The following is a description of a gene set: Human Gene Set: GSE20198_UNTREATED_VS_IL12_IL18_TREATED_ACT_CD4_TCELL_UP The aim of this study was to identify genes regulated by IL-12, IL-18 and IFN-alpha during early differentiation of human Th1 cells from publication Filén S, Ylikoski E, Tripathi S, West A, Björkman M, Nyström J, Ahlfors H, Coffey E, Rao KV, Rasool O, Lahesmaa R (PMID 20304822) Genes up-regulated in the activated CD4 T cells (48h): control versus IL-12 and IL18. species: Homo sapiens, and this is the list of marker genes: NDUFS6, SLC66A1, SYCP2, USP6NL, HAP1, AKR1C2, MYO5A, ASB13, PITX2, MT2A, ACOT8, LENG1, GRIN2D, ENTPD6, UNC13B, AGPAT3, WDR11, CYP4V2, NRARP, EPS8L1, PINK1, IDH3G, RAD51D, FOXO4 (NCBI Gene Id 4303), DVL3 (dishevelled segment polarity protein 3), CADM3, KCND1, FITM1, GPR180, MMRN2, PKDREJ, SLC25A28, KCNC2, KANSL3, ARHGAP28, WEE1, SNX7, MORN4 (NCBI Gene Id 118812), CSF2RA, PGS1, IRS2, DYNC2I2, FBXL18, TEX47, AK3, KCNAB2, C16orf90, MAP1S, AK4, SF3B2, RNF157, MAP3K2, LMAN2L, TREML2, STAG2, GET4, COL27A1, NKD2, NR1H2, LRP6, IKZF1, BCL2A1 (NCBI Gene Id 597), MYPOP, GRN, NONO, SLC25A40, RTN4RL1, ENTPD7 (NCBI Gene Id 57089), ZFP57, UBASH3A, HELB, EIF5A2, L1CAM, TCAF2, PTPRZ1, WDR7, PCBP2, RNF123, WDR82, KLHL22, RAB11FIP1, ADI1, BIRC7, HDAC1, ERGIC3, CASQ1, RNF19A, STX3, SEC22C, RBBP4, VSTM2A, SESN3, ULK2, ZFP41, CHSY1, THAP4, SEBOX, TRPC5, LRP10, SORT1, AARSD1, ANAPC2, ACSF2 (acyl-CoA synthetase family member 2), TLR7 (toll like receptor 7), DPYSL5, ABHD15 (NCBI Gene Id 116236), KLHL40, SOCS1, SH2D6, NACC1, PPP3CC, MAP7D1, FOXK2, MIA2, GNA11, SCCPDH, WBP2NL, GIPR, SETD1A, TEX19, PTK2B, TMTC4, TBC1D13, CCL13, CACUL1, NDUFC2, LSM14A, EPB41L5, ZP3, TERT, FSCN1, TMEM169, ACOX2, KIFBP (NCBI Gene Id 96724), GALR3, RANBP10, DUSP16, TTR, TNF, NAF1 (NCBI Gene Id 92345), C12orf75, SNRPA1 (small nuclear ribonucleoprotein polypeptide A'), RAI1, PGRMC2, PPP2R5C, PTPRG, COBL, CSNK1D, ELMOD3, RPA1, ZBTB11, CSRNP1, SIX5, CDC20B, PDXK, BCL7C, IL36RN, KIF3C, FGF4, TEX55, TOM1L2, EDA, APOBR, AGTRAP, DNAJC17, TLE4, RBM10, RMND1, RBPJ, PRRG4, NPPA, DNAJC12, TAS2R4, CACNA1C (calcium voltage-gated channel subunit alpha1 C), RIBC2, MLPH, FAM209A, IL34, FBXO34, HMGN3 (high mobility group nucleosomal binding domain 3), LUZP1, APLP1, GREB1L, SLC5A10, F5, CRIP2, SMURF1, NELFCD, CYFIP2, DRG1, RRM2B, UBR5, CDC14B, OSBPL7, NKX6-1, STRAP, MAPK7, ZNF414, NCBP1 (nuclear cap binding protein subunit 1)